The following is a description of a gene set: Genes containing one or more binding sites for (Hoxc12) in their promoter regions (TSS -1000,+100 bp) as identified by GTRD version 20.06 ChIP-seq harmonization. Mouse Gene Set: HOXC12_TARGET_GENES studied in species Mus musculus from publication Yevshin I, Sharipov R, Kolmykov S, Kondrakhin Y, Kolpakov F (PMID 30445619), and this is the list of marker genes: Ehd3, Tbc1d17, Ace, Gm454, Cenpn, Dazap1, Slc1a2, Hycc1, Zswim3, Ak5, Mir449c, Zdhhc7, Izumo4, Adgrd1, Mtcl1, Aldh6a1, Zmynd8, Tmem39a, Cox19, Map3k2, Fkbp1b, Setx, Rps19, Wrap73, Lamb2, Nradd (neurotrophin receptor associated death domain), Zfp646, Meak7, Akt1s1, Nrg4, 4930405L22Rik, Pcgf2, Ceacam2, Foxk1, Gm12216, Suox, Ccdc163, Bcl11a, Gm25438, Snord42b, Mib2, Slc47a2, Eps8l1, Ubtf, Clptm1l, Tcf4, Sinhcaf, Vcl, Acsf2, Gm11292 (predicted gene 11292), Hnrnpk, Fut7, Mogat1, Nudcd3 (NCBI Gene Id 209586), Ube4b, Nudt13, Gm16252, Ppp1r18, Emid1, Acsl1, Rasgrp2, Agrp, Arl6ip6, Xrcc4, Gm11690, Upk3bl, Tmem163, Mir8099-1, Zdhhc19, Arl10, Arhgap22, Mybpc2, Mcm8, Cyth3, Mir7080, Lss, Mid1, Rpl39, Angptl4, Sppl2a, Ncor2, Cabp1, Dhx33, Hip1, Paf1, Rab5c, Lclat1, Mbd6, Gm25498, Tra2b, Mir6974, Mir3960, Dop1b (DOP1 leucine zipper like protein B), 4930512B01Rik, Ighv1-66, Bpgm, Slc25a21, Gas7, Acad12, Dnajc17, Hnrnpa1, Plekho1, Lyrm7 (LYR motif containing 7), AA465934, Zfp523 (zinc finger protein 523), Adap1, Snrpd3, Tha1, Rsph14, Gm24453, Lta, Timm17b, Ces4a, Mrpl23, Prx, Igll1, Rpl10a-ps4, Mmp14, Amdhd2, Dennd1c, Gm2895, Rab3a, Inhca, Cbll1, Ppp1cb (NCBI Gene Id 231111), Perm1, Prob1, 4930463O16Rik, Traf3ip3, Scarb1, Prmt5, Tshr, Kmt5c, Ggta1, Dpf1, Mir6367, Rock2, Dmpk, Rab6b, Ano3, Akap7, Omp, Errfi1, Park7, Aak1, 5430402O13Rik, 4933439K11Rik, Rgl1, Mpst, mt-Te, Slc35a5, Zbtb26, Gm34106, Il2rg, Dnase2a, Aspscr1, Igkv2-109, Tor4a (torsin family 4, member A), Syne4, Dpp7, Gm13297, Stambpl1, Arf2, Mvb12b, Pank3, Celf6, Dbp, Vps33b, Neurl4, Rhof, Gm9522, Gm29241, Erich6b, mt-Th, Gm42161, Hectd4, F830208F22Rik, Tmem245, 3110070M22Rik, Snx29, Adamtsl2, 2010320M18Rik, Cdh23, Tcof1, Slc44a4, Cwc25, Mars1, Gtf2f1, Sned1, Trappc2b, Mrps15, Ddx19b, Gm15612 (predicted gene 15612), Gm26080, Rptor, Cux1, Phf14, Irf8, Bcl2l10, Cnot3, Chst3, Oasl1 (NCBI Gene Id 231655), Klf13, Nod2, Or13j1, Synj2bp, Aicda, Hes6, Gm12596, Lrrn3, Slc26a9, Nsun3 (NCBI Gene Id 77121), Trpa1, Gla, Camk2a (calcium/calmodulin-dependent protein kinase II alpha), Krba1, Dbn1, 1190005I06Rik, Tnfrsf23, Thap6, Pnn (NCBI Gene Id 52618), Epb41l4aos, Wdr38, Eif2b2, Sec16a, Fam168a, Lifr, Hpca, Usp39, Fli1, Arhgap25, 4930434B07Rik, Id2, Cibar2, Ccdc171, Sema4d, Capzb, Pla2g4a, Gmeb1, Ppm1f, Pik3ap1, Pidd1, Tmc5, Myl9, Hebp1, Baz1a, Mrpl27, Dyrk4, Cyrib, C920009B18Rik, Hat1, Clec4g, 2610318N02Rik, Mesd, Orai3, Erp44, Btbd19 (BTB domain containing 19, NCBI Gene Id 78611), Gm23344, Napa, Igkv1-135, Tifab, 4731419I09Rik, Hdhd2, Egfl7, Gramd1a, Igkv12-41 (NCBI Gene Id 636944), Arhgef3, Luzp1, Tomm40, Clcn7, Spocd1, Ubiad1, Gm16576 (NCBI Gene Id 100504191), Evc, Gm13268, Rpl18a, Zfp1008, Tonsl, Sapcd2, Snx5, Map9, Gm10286, Septin2, Lrwd1, Ybey, Mir7086, Rnaseh2b, mt-Td, Serpinb1-ps1, mt-Ts2, Bpifa5, Retreg2, Smim41, Akap8l, Fhip1b, Map2k6, Slu7, Pde4d, Gm11472, Creb3, 4930580E04Rik, Plch2, Mpnd, Fam78a, Gm15217, 3110040N11Rik, Il1r2, Snhg12, Rtn4ip1, Cd226, Gm17210, Enkur, Ankrd2, Plpp1, Son, Mapre2, AU019990, Fem1b, Gys1, Cmtm7, Siglecg, Mir3074-2, Hspa9, Hspa5, Zp1, Spag5 (NCBI Gene Id 54141), Gm28782, Lamc1, Tbl2, Crip1, Acp6, Steap3, Psme3, P2rx3, Chd9, Gm16104, Septin12, Hipk3, Ftl1, Cacnb2, Acbd7, Mrps33, Smc4, Atg4d, Ces1d, Pcsk4, Il12a, Mrps23, Zfp592, Gm12976, Atosb (atos homolog B), Sfpq, Washc3, Gm10778, Vamp4, Asap1, Map3k13, Cse1l, Mynn, Dpysl5, Pld3, Fetub, Clec4a3, Kcnt1, Wdhd1, Clk2, S100a10 (S100 calcium binding protein A10 (calpactin)), Pdia3, Lrrc3c, Rbm28, Gm10444 (predicted pseudogene 10444), Meltf (NCBI Gene Id 30060), Sf3b1, Pip4p1, Kmt5a, Slc12a6, Cpn1, Stamos, Hdac2, Iqcc (IQ motif containing C), Psmc4, Stard10, Pgk1, Ccdc47, Gm22863, Dapk3, Mapk10, Depdc5, Nipal3, Rbpms2, Taok1, Gpr137, 5330439K02Rik, Apold1 (NCBI Gene Id 631765), Mir8119, Kcnh3, Srpra, Gm13073, Atpaf1, Scly, Mdh1, Blvra, Zfyve19, Car14, Fnbp4, Ddx27, Pbld2, Cds2, Atp5mc2, Platr27, Mmgt2, Gm32200, Sh2d3c, Cnpy4, Hsd17b14, Gm29417, Rpl7-ps8, Sec14l2, C130026L21Rik, Timeless, Lsp1, Gm12017, Ntng2, Wbp11, Aldh7a1, Ezr, Chtf8, M1ap, Vps8, Dock2, Gm11205, Tiam1, Dda1, Iqcb1, 1700041G16Rik, Rpl36-ps9 (NCBI Gene Id 676902), Csnk1e, Xpa, Irak2 (NCBI Gene Id 74787), Gm29590, Tln1, Ninj1, Mir467e, Akt2, Gm3443, Cd40, Fcnb, Ttc39b (NCBI Gene Id 69863), Rab11fip4, Cc2d2a, Snx3, Stk25, Natd1, Dnaja3, Gm5535, Spata19, Sdc4, Mbd4, Ggnbp2, Dmwd, Zscan22 (zinc finger and SCAN domain containing 22), Pik3ip1, Recql4, Nfat5, Uhrf2, Iqsec1, Lck, Hdlbp, Mob3a, Mark2, Mir25, Srd5a3, Hnf1b, mt-Tl1, Rnf7, Ppp1r8, 5430405H02Rik, Cux2, Arrdc1, Aamp, Psma1, Cep63, Wasf1 (WASP family, member 1), Zfp384, Trappc3l, Arpc4, Cep290, Mpv17l2, 4933439J24Rik, Dnah1, Gm4189, Gas2, Phf21b, Wsb2, Ell3, Smim18, AU040320, Tcirg1, Rcc2, Zkscan17, Atp5mc1, Prkag3, Gm16322, BC004004 (NCBI Gene Id 80748), Susd3, 2310040G24Rik, Ank2, 4930555A03Rik, Dennd11, Bcl2l12 (NCBI Gene Id 75736), Rsrc2, Sap30bp, Tbc1d1, Tbx3os1, Pomp, Atxn2, Pank4, Tmem222, Tpst2, Ngdn, mt-Nd6, Ccl25, Gm15564, Gfi1b, Gm5855, Trbv16, Rab28, Pde4b, Gm8357, Mrps35, Rinl, Slc35b4, Robo2, Smpd3, Cpxm2, Spry2, Car11, Zswim2, Mir707, Zfp69, Mindy4b-ps, Arhgap18, Tor2a, Tnip3, Mthfr, Reno1, Gtpbp2, Zdhhc4, Prkag2, Igkv1-108, Pi16, Cfap276 (cilia and flagella associated protein 276), Itga4, Irag1, Tmem65, 4632404H12Rik, Impdh1, Abcf3, Lrpap1, Sgo1 (shugoshin 1), mt-Rnr2, Grk5, Gnas, Gadl1, Mcf2l, Mir374b, Atf7ip, Tpp2, Tcf25, Cngb1, Postn, Angel1, Gm26228, Akap1, Mapk11, Gipc2, Trim44, Btnl1, Ube2d3, Srbd1, Gm10222, Dzip1l, Gpr35, Isy1 (NCBI Gene Id 76060), Pdxdc1, Gm7364, Exoc3l2, Ppp1r11, Slfn5, Tnfaip8, Smtn, Oosp1, Exoc5, Anapc11, Paxbp1, Unc5cl, Arhgap27, 1700065D16Rik, Ergic1, Sh3bp4, Hexd, Mthfd2, Nap1l4, Rrm1, Gmfg, Samd14, Ndor1, Dus3l, Sult2a6, Fdxacb1, Mir22hg, Atp6v0a2, 2410002F23Rik, Ighv8-12, Myrf, 9130019P16Rik, Ubqln1, Alpl, Mrpl11, Etfb, Spn, Vars1, Strada, Megf9, Gm16894, Ezh1, Fat1, Dedd, Mrpl28, Relt, Grn, Tmprss11b, Hgd, Tnfrsf26, Epn1, Mir8111, Ank1, Mamdc4, Fam110a, Cfap68, Ctxn3, Stat4, Pkn2, Pkn1, Dok3, Or1o4, AI467606, Arap1, Cdkl1, Chchd4, Smdt1, Ube2e3, Sardh, BC043934, Tet3, Fbxo30, Fam234a, Gm35409, Map6d1, Eif2s2, Syne3, Tmem135, Zfp143, P2ry6, mt-Nd1, Etv4, A930009A15Rik, Ap5m1, Pde2a, Snora61, Nr6a1, B3gntl1, Astl, Gm40330, Wapl, Atp8b2, Sec24a, Limk1, Phpt1, Tbc1d24, Or2y1, Poglut3, Spata13, Tmem80, Ighv1-67, Mir709, Ubn1, Snord99, Selplg, Fyn (Fyn proto-oncogene), Ahcyl2, H2-Eb2, 4931440P22Rik, Atr, Polr1e, Begain, Gm525, Dna2, Tk2, BC028528, Ablim1, Mir466p, Was, Cdc42ep3, Rab40c, Cdc5l, Myo7a, Esd, 4930519G04Rik, Lasp1, Gm8813, Gm22039, Ruvbl2, Sash3, Socs4, Nek2 (NCBI Gene Id 98226), Ebf1, Ift81, Zpbp, Fstl1, Trim25, D2hgdh, 1700047F07Rik, Hnrnph3, Topbp1, Psme2, Tmem210, Aktip, Ddit4, Gprin2, Zkscan6, Irak3, Mia2, Abhd11, Ccnf, Sesn2, Muc5ac, mt-Tv, Tmie, Hk2, Cdcp2, Ift122, Timm13, Gm16291, Slc11a2, Hira, Tnk2, Grin1, Cdc20b (cell division cycle 20B), Tlnrd1, Nthl1, Tanc1, mt-Ta, Elapor1, Glo1-ps, Kcnk4, Rln1, Sde2, BC049715, Ipo13, Dlgap4, Gm23126, Atf5, Eml6, Parp16, Pold4, Pqbp1, Catsperd, Shb, Ints3, mt-Tq, Rnaseh2a, Ptpa, Bcl3, Aph1a, mt-Co1, Alad, Cdk19os, Ddx42, Gm18727, Csnk1g2, Rmi1, Actr6, Zc3h7a, Abhd17a, Zbtb42, 1700086O06Rik, Llgl1, Dnajc21, Ak1, Cntn2 (contactin 2), Gm16341 (NCBI Gene Id 102634967), Rnase2b, Ddx5, Pick1, Ugt1a6a, Coro1a, Ifi211, Mul1, H2-Ab1, mt-Ty, Selenov, Dnaaf9, Gm10250, Wiz, Ppp2r5d, Rac2, Gm14343, Ciz1, Gm38331, Pde11a, Irf1, Lonp1, A730017L22Rik, Lin52, Gm22744 (predicted gene, 22744), Gm8000, mt-Tc, Tcf7, Mir93, Fastk, Stxbp1, Vamp1, Mir7000, Lrrc74b, Mir374c, Phlpp1, Ier3ip1, Mir5134, Ezh2, Usp21, Cic, Tef, Rhobtb2, mt-Tn, Rab36, Tnni2, Cmc2, Haus8, 5730488B01Rik, Igkv2-116, Zfp706, Tgif1, Plcb2, Kcng1, Krr1, Vps33a, Katnip, Hdac10, Zfp146, Ttyh3, Hinfp, Hsp90aa1, Mif, Gm11903, Asb17os (NCBI Gene Id 72317), Tmem267, Gm15247, Lman2, Map4k2, Rgs10, Cops4, Hip1r, Gpr19, 1700028E10Rik, Gm16316, Sntn, Gm29538, Gm4865, Ubqln4, Ak2, Lypd5, Tsfm, Gm12915, Mad2l1bp, Gm23639, Golga1, Slc30a5, Tmem170, Ubxn11, Itih5, Mcts2, Ifnar1, Zdhhc12, Fut10, Cenps, Acy1, Gm24751, Ints8, St8sia4, Atp6v0d1, Snx17, Slc7a9, Nosip, Tfeb, B3gnt3 (UDP-GlcNAc:betaGal beta-1,3-N-acetylglucosaminyltransferase 3), Pkig, Izumo1 (izumo sperm-egg fusion 1), Spata31e2, Glcci1, Bbs4, Gm12843, Septin1, Slc25a23, Rtca, Apobec4, Atp6ap1, Ctsc, Dusp2, Cd79b, Cep95, Afmid, Gm20753, Afg2a, Gm43380, Map3k10, Tfb2m, Ndufb7, Fscn2 (NCBI Gene Id 238021), Tnr (tenascin R), Arfgef2, Fam53b, Gm27011, Pkdcc, Recql5 (RecQ protein-like 5), Rtkn, Ttc3, Csnk1g1, Nsmce4a, Gm21411, Nr4a3, Brpf3, Or5t19-ps1, Dusp15, Pttg1ip, Opn3, Prmt3, Vdac2, Gm22203, Snx1, Pank2, Osbpl10, Rab2b, Amz2, Arhgap39, Gfy, Eif2b4, Atp6v1b2, Slc12a4, Pik3r2, Cd22 (NCBI Gene Id 269895), Pomt1, Mmp9, Brox (NCBI Gene Id 71678), Kcnk13, Gm13270, Tekt1, Dhrs3, Slc23a2, Grhpr, Smg5, Mirt1, Mir301b, Irf7, Gbf1, Gpr142, B3gat1, Arid5a, Adgrg1, Gm22534, Ppm1a, Kdm4a, Cep250, Bhlhe41 (NCBI Gene Id 79362), Crebrf, Gm18341, Meikin, Abr, Mgme1, Arhgef17, Lfng, Pcolce, Rnf145, Trpm8, Stard6, Spag6, Cpeb3, Tmbim4, Spink8, Hvcn1, Rbm17, Arhgef19, Tfr2, Hrh1, mt-Tt (NCBI Gene Id 17744), Hmgcll1, mt-Tw, Fuca2, Gm24223 (predicted gene, 24223), Polr2g, Hmces, Npm2, Ddx51, Snupn, Ppp1r16b, Il16, Exoc7, Mir7032, Oasl2, Cnppd1, Ormdl3, Trim47, Ciao2b, Tnrc6c, Rab10os (RAB10, member RAS oncogene family, opposite strand), Rassf2, Nfe2, Dennd3, Pfkfb4, Akap12, Top3b, Mnt, Abtb1, Rangrf, Myd88, Nupr1, Kcnq5, Gm5893, Twf2, Plekhm1, Cep170, Nutf2, Zfat, Naglu, Slc25a46, Epha5, Cmtr1, Ppp1r16a, Rpl23a, Por, Dennd4b, Cd82, Slc38a10 (NCBI Gene Id 72055), D930032P07Rik, Letmd1 (NCBI Gene Id 68614), Trim2, Gm11400, U2surp, Upf3b, Hsp90b1, Chchd2, Cdnf, Plekhg2, Ptpn6, Mcm7, Rab5a, 1700034H15Rik, Ero1b, Gm13203, Gtf2a1, Ifitm3, Mxd3, Acot8 (acyl-CoA thioesterase 8), Fam237b, Il2ra, Cited2 (Cbp/p300-interacting transactivator, with Glu/Asp-rich carboxy-terminal domain, 2), Ighv8-14, Alkbh7, Sh3tc1, Pcca, S100a3, Eif4g1, Oxnad1, Niban3 (NCBI Gene Id 100037278), Vim, C030037D09Rik, Tmed2, Rpl38, Gm10062, Tmtc3, Tkt, Myh14, Zcchc8, Cdc37l1, Gstt3, Ankrd63, Ppp2r5a, Pxk, Igkv2-112, Mpc1-ps, Prkrip1, Rcsd1, Pold1, Klf9, Caskin2, Zfp287, Pate2, Igkv2-137, Bcl7c, 2810408A11Rik, Sox5os5, Dgat1, Lrrc32, Il21r, Gm17025, Gm20788, Ankhd1, Gsk3a, 4933439C10Rik, Gm13524, Zfand2a, Gsn, Rpsa-ps3, Pou2af1, Hras, Mir2861, Ppp2r2d, Ccl9, Th, Itga6, Fkbp7, St6galnac6, Dhrs7b, Camp, Calm1, Gpr37, Mthfd1l, Ubxn1, Sh3pxd2a, Med29, Ncoa3, Ints9, Pafah2, Gna15, F8, Trdv3, 4930412F09Rik, Ankrd46, 1700113A16Rik, Tnpo3, Gm11738, Hsdl2, Nop14, Ptch1, Cycs (NCBI Gene Id 13063), Fcrla, Vsir, Got1, Samd15, Prkcd, Rffl, Gbp9, Tpo, Awat2, Itln1, Dus2, Leng8, Stat1, Rpl13a, Il6ra, Parp4, Pde8a (NCBI Gene Id 18584), Phactr2, Plxnb2, Trim66, Mir466f-4, Thrap3, Tox4, Zfp629, Brd2, Faap20, Rnpep, Jade1, 1700036A12Rik, Sfi1, Gm23692, Osbpl9, Amn1 (NCBI Gene Id 76107), Phip, Eif2ak1, Ppox, Dnase1l3, Or10aa1, Gm25056, Ppp2r5b, Arl8a, Smc6, Ipmk, Or1o3, Slc10a6, Tex44, Akap10, Arhgef1, Il4i1, Zfp219, Cfap251, Ucp2, Rai1, Gm13528, Fbxo46, Pan3, Mzf1, Pex11a, Ptpru, Diablo, Ercc6l2, Tpd52, Igfbp2, Dph3, Gm15850, Slc37a3, Tmcc3, Canx, Fam111a, Pepd, Gm22680, Gmip, Rchy1, Nlrp1a, Slc5a11, Septin9, Grep1, Mocs1, Elp5, A230059L01Rik (RIKEN cDNA A230059L01 gene), Matk, Zbtb6, Ckap2l, Gm14023, Rora, Odad4, Jag2, Slc11a1, Plxna3 (NCBI Gene Id 18846), Slc35f6, Plek, Nr0b2 (NCBI Gene Id 23957), Gm22593, Rn7s6, Pnkd (paroxysmal nonkinesiogenic dyskinesia), Best3, Rassf1, Pknox1, Cd69, Nfic, Gm24452, Glis3, Strn3, Tle2, Hs6st1, Agpat5, Zfp998, Ptdss2, Eif3a, Cdc25b, Fignl1, Eme1, Tac4, Zfp663, Hmgcr, Rmdn1, Dalrd3, Abhd1, Ndrg1, H2-D1, Pi4k2a, Dnase1, Rbmxl1, Wdfy4, Ccs, Acaa1a, mt-Cytb, Lsmem1, Mir8094, Ube4bos3, Chaserr, Gm6665, Golph3, Smad6, B9d1, Adsl, Rasal1, Ddx31, Phka1, Il6st, 1700074H08Rik, Abi3, mt-Nd2, Ttc33, Clic1, Copg2, Klhdc8b, Hfe, Apbb1, Calhm3, Map2k1, Amigo1, Suz12, Klk4 (kallikrein related-peptidase 4 (prostase, enamel matrix, prostate)), Nr1d1, Gskip, Hapln2, Wt1, Top2b, Gcnt1, 4930503L19Rik, Mgat4a, Grk4, Trpv2, A430005L14Rik, Ehbp1l1, Ate1, Reep6, Gm18430, Ccdc18, Erich3, Mphosph8, Mpdu1, Mterf2, Catsper2, Mbnl1, Cd79a, Ube2q1, Snord35b, Plekhh3, Sacs, Hddc3, Spsb4, Midn, Bbln, Ceacam1 (NCBI Gene Id 26365), Nipsnap3a, Mir421, Gm13837, Anks1, Mir6769b (NCBI Gene Id 102466799), Supt5, Ppp2r1a, Acly, Gm6872, Dnajc8, Tada3, Cyp2d22, mt-Nd5, Nt5c3b, Vps26a, Hoxa7, Zfp688, A430027C01Rik, Msl1, BC046401, Tbc1d22b, Etnk1, Aurkaip1, Eef1akmt2, Prpf19, Toe1, Cdk9, Arhgap4, 4930455G09Rik, Neil1, Gatd3a, Stpg1, Zmynd10, Ccm2, Tulp2, Shank1, Drc7, Myadml2, Zeb2, Calm3, Nupr2, Pcdhac1, Gm23329, Gm23246, Slc15a3, Klk11, Cul2, Gm28877, Gngt2, F830115B05Rik, Pnpt1, Mis12, Ifitm2, Mmachc, Nat10, Pianp, Alkbh8, Mical2, Vcan, LTO1, Pten, Laptm5, Slc17a9, Il1rn, Cd9, Tnip1, Gm15879, Ift140, Tmem69, Tmem167, Trim40, Ctdnep1, Adgrd2-ps, B230354K17Rik, Zfp668, Ighv4-1, Gm37450, Lep, 2210408F21Rik, Arpc5, Tceanc, Ncf4, Wdr93, Epha4, Entpd7, Hmbox1 (NCBI Gene Id 219150), Kif23, Camk2d, Tsen54, Arfip1, Hhex, Atp5me, Pcna, Mettl21a, Mir690, Agtpbp1, Ube2i, Snx8, Ccdc12, Nbeal1, Hmcn2, Mon2, Ift80, Gm8093, Mageb3, Pygm, Plgrkt, Ubxn8, 1700019D03Rik, Ywhag, Ldb3, Dll1, Ctdspl2, Pxn, Sypl1, Pgs1, Mef2c, 1700008O03Rik, Col9a2, Dnaja1, Dnajc13, Flot1 (NCBI Gene Id 14251), Csf1, Dapk2, Pcgf1, 9930014A18Rik (RIKEN cDNA 9930014A18 gene), Invs, Rundc3b, E030018B13Rik, Setdb2, Stam, Gabrb2, Trmt9b, P3h1, C78283, Gm11399 (NCBI Gene Id 108167875), Ttll9, Rplp1rt, Pole2, N4bp2l1, Cab39l, Yipf1, Gm28417, Morc3, Cep295, Actl7b, Gm13141 (NCBI Gene Id 545718), G530011O06Rikx, Tst, Ccng2, Syt11, Gm15663, Tubg2, Cpne3, 2810454H06Rik, Sh3rf3, Mir29c, F730311O21Rik, Bco1, Olfm5, Tbcd, Gm17590, Arhgap45 (NCBI Gene Id 70719), Tbrg4, Ggt7, Guca2b, Hcar1, Gm24411, Zfp664, Rab37, Bad, Dele1, Rassf4, Creld1, B2m, Parp9, Gm24917, Nrxn2, Fgd3, 5031439G07Rik, Paip2, Gm12576, Ppp1r12c, Acsl6, Taf6, Lrrfip1, Slamf7, Tmed5, Serpinb6b, Cdkn2aipnl, Tmed8, Prlr (NCBI Gene Id 19117), Clcn6, Mroh1, Mir6236, Usb1, Mir142hg (Mir142 host gene (non-protein coding)), Kif20a, Naga, Spint1, mt-Tl2, Gm10631, Nsun5, Orc3, Duxf1, Flywch1, Mindy3, Efhd1 (NCBI Gene Id 98363), R3hcc1, Ugt1a7c, 4930451I11Rik, Pdlim2, Cbx5, 1700003F12Rik, Lamtor2, Rgs19, Rhoh, Scrn3, Ndel1, Traip, Rabif, Pheta2, Isoc2b, Itga2b, Cdc40, Mta3, Rabgef1, 1700001K19Rik, Fes, Gm10748